The following is a description of a gene set: Human Gene Set: GOBP_PEROXISOME_ORGANIZATION species: Homo sapiens A process that is carried out at the cellular level which results in the assembly, arrangement of constituent parts, or disassembly of a peroxisome. A peroxisome is a small, membrane-bounded organelle that uses dioxygen (O2) to oxidize organic molecules., and this is the list of marker genes: PEX3, PEX11G, TMEM135, ABCD3, ACOX1, USP9X, ABCD2, HACL1, PEX5L, FIS1, PEX11B, PEX10, PEX14, PEX19, PEX26, DNM1L, PEX16, OPA1, ABCD1, CRYZL2P-SEC16B, LONP2, ACOT8, TRIM37, PEX5, RAB8B, PEX11A, PEX1, PEX6, PEX7, ZFAND6, MAVS, MFF, SEC16B, PJVK, ABCD4, PEX12, PEX2, PLAAT3, PEX13 (peroxisomal biogenesis factor 13)